Given this list of marker genes Rasgrf2, Rwdd1, Dlgap2, Cdk5r1, Ppara (NCBI Gene Id 399624), Shank1, Dapk1, Tafa1, App, Cav3, Socs4 (suppressor of cytokine signaling 4), Neurl1a, Crh, Reln, Ppp2r5b, Fbxw7, Adam17, Park7, Cnih3 (NCBI Gene Id 72978), Zp3, Ramp3, Cacng2, Adra2b, Neto1 (neuropilin (NRP) and tolloid (TLL)-like 1), Cblc, Hdac6, Nlgn2, Grem1, Tsg101, Cacng4, Adra2a, Cnih2, Hdac1, Homer1, Gprc5a, Nlgn1 (neuroligin 1), Cga, Pparg, Adra2c, Lrp8, Begain, Cnrip1, Rasgrf1, Ppp2ca, Adrb2, Cacng3, Il24, Hfe, Nrxn2, Gsg1l, Il20, Il19, Slurp2, Oprm1, Pcsk9, Psca, Nlgn3, Notch1, Shisa9, Ankrd13c, Phlda2, Mink1, Hif1a, Cacng5, Psen1, Zgpat, Cacng7, Fshb, Homer3, Bud31, Crhbp, Lynx1 (NCBI Gene Id 23936), Grem2, Nog, Lilrb4b, Chmp6, Aplp2, Tafa4, Shisa7, Errfi1, Zfyve28, Ldoc1, Calcr, Prrt1, Tnf, Socs5, Serpine1, Mapk8ip2, Chrna5, Ptprj, Ace2, Lilrb4a, Plau, Hdac2, Vps25, Pate4, Psen2, Cacng8, Thap11, Edn1, Il10, Clec12b, Shisa6, here is a description of the gene set: Mouse Gene Set: GOBP_REGULATION_OF_SIGNALING_RECEPTOR_ACTIVITY Any process that modulates the frequency, rate or extent of a signaling receptor activity. Receptor activity is when a molecule combines with an extracellular or intracellular messenger to initiate a change in cell activity. species: Mus musculus